Given this list of marker genes MCF2, ARHGEF4, ARHGEF17, ARHGEF18, OBSCN, NET1, VAV1, ARHGEF40, ARHGEF2, ARHGEF10, ARHGEF15, ARHGEF3, ARHGEF33, MAGED1, ARHGEF16, ARHGEF1 (NCBI Gene Id 9138), NGEF, NGFR, ARHGEF37 (NCBI Gene Id 389337), ARHGEF5, ARHGEF9, AATF, TIAM1, ARHGEF38, RAC1, ARHGEF12, PLEKHG2, MCF2L, FGD3, BCL2L11, AKAP13, KALRN, ARHGEF26, BAD, ARHGEF39 (Rho guanine nucleotide exchange factor 39), TRIO, FGD1, GNA13, FGD2, PREX1, SOS2, ARHGEF10L, MAPK8, TIAM2, ECT2, ABR, RASGRF2, ITSN1, PLEKHG5, VAV2, SOS1, NGF, ARHGEF6, ARHGEF7, FGD4, ARHGEF35, ARHGEF19, ARHGEF11, VAV3, here is a description of the gene set: NRAGE signals death through JNK studied in species Homo sapiens Human Gene Set: REACTOME_NRAGE_SIGNALS_DEATH_THROUGH_JNK